Given this list of marker genes LIPT2, SLC31A2, DDI2, PABIR1, HAND1, CCND2, SLC5A9, ENTREP2, SLC20A1, YPEL2, KLHDC8B, MFSD4A, ADRB3, MIB1, TET3, PRPF38B, CARNMT1, COL3A1, FNIP2, CNTRL, DDX19A, CEP120, SKIL, TMC7, SLC22A23, SCN4B, ADRB2, PRSS22, GABBR2, ZSWIM5, SPRYD4 (NCBI Gene Id 283377), POGLUT1, ABCC5, TNFSF9, ERO1A, TMPPE, SIGLEC14, YOD1, PDE12, IL13, RGS16, PLEKHA8, IGF1R, LAMP2, GTF2I, MTUS1, ATOSB, HOXA1, SOCS4, E2F6, TRANK1, PPP1R16B, ZBTB5, PGRMC1, CERT1, SALL4, GCNT4, VIRMA, HECTD2 (NCBI Gene Id 196026), ACVR1C, KIAA0930, DIP2A, RNF20, XRN1, TBKBP1, KDM3A, ZNF710, ASAP1, ZNF784, FRMD4B, CDC25A, PALD1, NPEPL1, B3GNT7, ERCC6, TMEM121B, STX3, ZNF280B, GALNT1, NRAS, PXDN, RFX6, SMC1A, SRD5A3, SIGLEC5, CLDN16, IMPG2, AGO4, MYCN, NYNRIN, COL4A6, AEN, GATM, ATP2A2, LIN28A, PBX2, KLHL31, PLPP5 (phospholipid phosphatase 5), CLCN5 (chloride voltage-gated channel 5), MEIS2, BIN3, IGF2BP2, IKZF2, GALC, TECPR2, DNAJC1, KCTD17, SENP2, DTX2, GFM2, BZW1, E2F2, TMEM234, PIGA, MMS22L, C8orf58, CPEB2, LEPROTL1, DNAJA2, WDR37, ARID3B, NPHP3, TMOD2, PCDH19, GALNT2, ANKRA2, MARS2 (NCBI Gene Id 92935), BSN, ACSL6, COIL, GAS7, NIPAL4, POGZ, MED8, TRIM71, EEA1, PXT1, DLST, KCNJ11, PPP1R15B, FASLG, PDPR, STK40, EDN1, UTRN, CDC34, DLC1, AMT, RSPO2, MAP3K1, PLAGL2, HOOK1, LBR, FZD4, SLF2, MAPK6, GOLT1B, TRIM67, AHCTF1, ZCCHC9, CD164, GPCPD1 (NCBI Gene Id 56261), IQCB1, PLEKHO1, INSR, WNT9B, EPHA4, STARD9, DVL3 (dishevelled segment polarity protein 3), PRLR, RALB, KLF8, LIN28B, SESTD1, ARL5A, ONECUT2, PTPRD, XKR8, SDK1, GJC1, GYG2 (NCBI Gene Id 8908), HDLBP, CCL7, VCF1, EDEM3, SNX30, IRS2, PAPPA, AMOT, E2F5, HIP1, LINGO1, DUSP1, SLC10A7, FZD3, KCTD21, LRIG2, XYLT1, RBFOX2, NHLRC3, VAV3, FNIP1, TMEM65, OPA3, UHRF2, SMIM3, SENP5, SALL3, C14orf28, GNG5, DPH3 (NCBI Gene Id 285381), MAPK8, HAS2 (NCBI Gene Id 3037), NME4, RAB11FIP4, MTDH, CPA4, PRTG, STARD3NL, SLC25A27, OSMR, CPEB3, HDX, PBX3 (NCBI Gene Id 5090), USP38, ERCC4, ELF4, ARHGAP28, ZNF322, PARPBP, THOC2, TMEM167A, C19orf47, CHD4, UGCG, HMGA2, MAP3K9, B4GAT1, IGDCC4, PLXNC1, ZNF275, ARMT1, SCD, PARP8, POLR3D, BEGAIN, CLP1, SEMA4C, HSPA14, MEF2C, KLF9, ADAMTS8, INTS6L, CRTAM, GAN, ITGB3, SLC5A6, SMARCAD1, DDX19B, FGF11, TGFBR3, FBXL12, CDKN1A (NCBI Gene Id 1026), ZNF644, DTX4, GDF6, USP24, ARK2C, CLDN12, IGDCC3 (NCBI Gene Id 9543), GNPTAB, ABL2, MRS2, ARID3A, GPATCH2, STIMATE, CASP3, PTAFR, KIAA1958, GXYLT1 (NCBI Gene Id 338841), HIC2, DHX57, COL4A2, FIGNL2, FGD6, DPP6 (NCBI Gene Id 653748), PLA2G3, IGF2BP3, THRSP, ATL2, PBX1, GRPEL2, EIF4G2, DUSP22, SLC2A12, LIPH, APBB3, CD59, ACVR2A, ZBTB8B, DDTL, CPEB1, ESR2, DNAAF9, FNDC3A, RDX, RUFY3, OSBPL3, SRGAP1 (NCBI Gene Id 57522), FIGN, CEP135, PLXND1, FNDC3B, ABCB9, ZFYVE26, RASGRP1, PEX11B, SLC35D2, ADAMTS15, TSPEAR, NGF, AP1S1, FAM135A, ACER2, ABT1, ZNF583, RIMOC1, LPGAT1, TAF9B, STRBP, SLC38A9, SEMA4G, BEND4, MDM4, ELP1, DNA2, MAP4K3 (NCBI Gene Id 8491), CBX5, USP44, SUB1, PIK3IP1, CCNJ, DCUN1D2, COL5A2, COL4A1, AKAP6, LRIG3, MBD2, EEF2K, ZNF512B, PLPP6, LIMD2, TSEN34, C15orf39, TTLL4, NKAPD1, ZBP1, PCGF3, SCN11A, SFMBT1, NEK3, ZNF689, EFHD2 (NCBI Gene Id 79453), TMPRSS2, BACH1, ARHGEF38, NME6, GPR26, COL27A1, CERCAM, SLC16A9, ZNF516, RGS6, MASP1, RANBP2, DCAF15, POLL, ARG2, ENTPD7, CNOT6L, STARD13, KCNC2, HOXD1, NR6A1, COL1A2, SNX16, XK, ACTA1, CADM2, ATP8B4, HIF1AN, FAXC, FRAS1, NAP1L1, CEMIP2, IGF2BP1, DMD, RAB8B, PLEKHG6, PEG10, AGAP1, TGFBR1, RICTOR, here is a description of the gene set: studied in species Homo sapiens Genes predicted to be targets of miRBase v22 microRNA hsa-let-7g-5p in miRDB v6.0 with MirTarget v4 prediction scores > 80 (high confidence targets). from publication Chen Y, Wang X (PMID 31504780) Human Gene Set: LET_7G_5P